Given this list of marker genes SLC17A7, LINC01435, PROKR1, ABCA15P, SATB2, MPPED1, LINC01965, SMIM34, NAV2-AS2, HMGN1P14, SLC26A4, FABP7P1, LINC02232, RGS21, PPEF1, TBR1, GSCAR, IQCF3, GALNT5, ALOX15, ITPRID1, FEZF2, NPR3, NEUROD2, MTATP6P15, here is a description of the gene set: species: Homo sapiens from publication Cao J, O'Day DR, Pliner HA, Kingsley PD, Deng M, Daza RM, Zager MA, Aldinger KA, Blecher-Gonen R, Zhang F, Spielmann M, Palis J, Doherty D, Steemers FJ, Glass IA, Trapnell C, Shendure J (PMID 33184181) The gene expression program underlying the specification of human cell types is of fundamental interest. The study authors generated human cell atlases of gene expression and chromatin accessibility in fetal tissues. For gene expression, the study authors applied three-level combinatorial indexing to >110 samples representing 15 organs, ultimately profiling ~4 million single cells. The study authors leveraged the literature and other atlases to identify and annotate hundreds of cell types and subtypes, both within and across tissues. Our analyses focused on organ-specific specializations of broadly distributed cell types (such as blood, endothelial, and epithelial), sites of fetal erythropoiesis (which notably included the adrenal gland), and integration with mouse developmental atlases (such as conserved specification of blood cells). These data represent a rich resource for the exploration of in vivo human gene expression in diverse tissues and cell types. Human Gene Set: DESCARTES_FETAL_CEREBRUM_EXCITATORY_NEURONS Marker genes curated from the annotated cluster as represented in the Descartes Human Gene Expression During Development database.